The following is a description of a gene set: Human Gene Set: ZHONG_PFC_MAJOR_TYPES_MICROGLIA from publication Zhong S, Zhang S, Fan X, Wu Q, Yan L, Dong J, Zhang H, Li L, Sun L, Pan N, Xu X, Tang F, Zhang J, Qiao J, Wang X (PMID 29539641) species: Homo sapiens, and this is the list of marker genes: FCGRT, SPP1, C1QB, ZFP36L2, CCL4L2, GLUL, RHOB, MPEG1, LINC00996, NPL, CREG1, SASH3, IRAG2, C2, MAF, MNDA, TGOLN2, HLA-C, FOLR2 (NCBI Gene Id 2350), ADAP2, TAPBP, RNASET2, JUNB, RGS2, CH25H, MBNL1, RAB3IL1, A2M, S100A11, CORO1A, PALD1, SERPINB6, NABP1, BIN2, LTC4S, B2M, STING1, GALNT1, SRGN, HSPA1B, ARPC1B, AIF1, PLEK, TBXAS1, PLTP, RNF135, SLC9A9, VSIG4, LAIR1, KCTD12, SIRPA, IFI16, MGST2, TMIGD3, SLC7A7, P2RY13, RASSF4, ADISSP (NCBI Gene Id 54976), IRF8, HVCN1, IGF1, FLI1, SIGLEC8, FYB1, ARHGAP4, SAMSN1, ARHGDIB, CCL3, SLC29A3, RPS6KA1, ANXA11, ELF1, RNF13, CD37, ENTPD1, DPP7, P2RY12, FOS, ADA2, LGMN, REEP4, TNFRSF1B, RAB32, RBMS1, CCND1, XBP1, PTPRC (protein tyrosine phosphatase receptor type C), HERPUD1, LAMP1, RCSD1, JAG1, FAM78A, LAMP2, FCGR2A, LIPA, TMIGD2, MGAT4A, STXBP2, TLR7, LYST, GMFG, FOSB, PLXDC2, RYR1, TLR4, OTULINL, HLA-B, CIAO2A, ADORA3, ATP2B1-AS1, GNG7, APOE, C3AR1, ALOX5, DHRS3, GRN, C12orf75, ATP8B4, B3GNT5, MSN, ABCG2, IL10RA, IL6ST, HCK, TNFAIP8L2, SCAMP2, SCAF11 (NCBI Gene Id 9169), PLD3, RAPGEF6, ADAM9, RHBDF2, PDK4, OAS1, ZFHX3, EVI2A, DOCK4, IGSF6, ITM2B, CEBPA, HLA-E, LPAR6, PDPN, PLD4, TAGAP, WASF2, SOCS6, CCR1, SELPLG, FCGR1BP, MFSD1, TMEM35B, GNAI2, MANBA, GNG5, IPCEF1, IL16, RUNX1, HPGDS, CD36, STOM, LY86, ASAH1, JUN, NAGA, HSPA1A (NCBI Gene Id 3303), LINC01094, SERPINA1, CNPY3, TNFRSF1A, LAT2, CEBPD, RIN2, UCP2, ABHD12, SFMBT2, C1QA, PARVG, SMAP2, CD53, HCST, IL13RA1, P2RX4, TPP1, FPR1, BTG2, CTSC, DAB2, MYLIP, ZFP36L1, FES, PTPN6, AOAH, LST1, PTPRE, CD164, ARRB2, IL17RA, BRI3 (NCBI Gene Id 25798), NCF4 (neutrophil cytosolic factor 4), TIMP2, H1-2, LINC02256 (long intergenic non-protein coding RNA 2256), CAPZB, SALL1, CD83, CX3CR1, MED12L, CD63, PSAP, HEXA, SIPA1L2, IFNGR1, GATM, LIMS1, CPVL, CD84, CXCL16, NEAT1, TACC1, OLFML3, MYO1F, EGR3, APBB1IP, TAL1, MIS18BP1, BHLHE41, PLCB2 (phospholipase C beta 2), SERPINF1, VAMP8, TMT1A, NAIP, SH2B3, FCER1G, MILR1, DOCK2, ATP6V0E1, SYNGR2, LHFPL2, CD74, PFN1, C3, PLA2G15, TM6SF1, STAB1, RAB31, TSC22D3, SYK, APOC1 (apolipoprotein C1), AP1B1, ANXA5, SLCO2B1 (solute carrier organic anion transporter family member 2B1), ACTR2, LPAR5, MAST3, PLVAP, SLC7A8, IER2, CYBB, NCKAP1L, C1QC, MPP1, ITGAX, FMNL3, GLIPR1, FCGR3A, TMBIM1, CREBL2, APPL2, EGR2, HTRA1, DNAJB1, CTSD, RGS1, TYROBP, CPED1, ITGAM, PRR13, ARHGAP9, GM2A, GIMAP4, FCGR1A, NR4A2, GAA, TCIRG1, MAN2B1, SIGLEC10, EGFL7, SPRED1 (NCBI Gene Id 161742), LPCAT2, EGR1, ABI3, GNB4, MRC1, CASP1, TLN1, TMC6, IFITM2, MYH9, LAPTM5, RAB29, IER3, PYCARD, KLF2, SP100, GAS6, FGD2, HAVCR2, CYBA, ZFP36, HEXB, BIN1, NINJ1, OLR1, GADD45B, CD14, FCGR1CP, CYFIP1, P3H2, OTUD1, INPP5D, WDR91, CTSA, GPR34, KLF6, CD86, DNPH1, PSMB10, DUSP1, DOCK8, GPR183, HCLS1, CSF3R, ADRB2, NAA20, TMEM119, POLD4, SORL1, NRIP1 (NCBI Gene Id 8204), C5AR1, TMEM273, RGS19, PAG1, RB1, ITM2C (NCBI Gene Id 9523), ANXA4, CD68, MYL12A, LPIN2 (lipin 2), MS4A7, TPT1, LCP1, NFKBIA, GAL3ST4, PTAFR (platelet activating factor receptor), LYN, IL6R, GSTK1, TMEM52B, SMIM30, PTGS1, RNASE6, DHRS9, OSTF1, CSF1R, TFEC, RNF130, COLGALT1 (NCBI Gene Id 79709), NR4A1, BLVRB, ADAM28, SGK1, IFI30 (NCBI Gene Id 126359), VSIR, GGA2, ITGB2 (NCBI Gene Id 3689), TLR10, PPT1, VAV1, MKNK1, CAP1, SAT1, CMTM6, MIR23AHG, RGS10, RUBCNL, SFT2D1, CTSB, GGTA1, ATM, GSN, MEF2A, SLC15A3, GPSM3, MERTK, GPX1, CCL4, LINC02712, AXL, VMP1, CD300A, APLP2, RPH3AL-AS1, NPC2, CMTM7, RHOG, NEU1, PDGFB (NCBI Gene Id 5155), GPN3, PLA2G7, BST2, BLNK, IGFLR1, CTSS, CD81, GYPC, ALOX5AP, SESN3, NR3C1, WAS, IKZF1, FTL, ARHGAP12, ACY3, FRMD4A, SWAP70, PPP1R18, SLC29A1, RCN3, CD4, RNF213, MGAT1, CRYBB1 (crystallin beta B1), TREM2 (NCBI Gene Id 54209), LILRB4, LY96, ITPR2, CYTH4, CTSL